The following is a description of a gene set: species: Mus musculus Genes down-regulated in NIH3T3 cells (fibroblasts) after treatment with Y27632, an inhibitor of ROCK proteins; the changes did not depend on expression of constitutively active (Q63L) form of RHOA. Human Gene Set: BERENJENO_ROCK_SIGNALING_NOT_VIA_RHOA_DN from publication Berenjeno IM, Núñez F, Bustelo XR (PMID 17213802) We have used microarray technology to identify the transcriptional targets of Rho subfamily guanosine 5'-triphosphate (GTP)ases in NIH3T3 cells. This analysis indicated that murine fibroblasts transformed by these proteins show similar transcriptomal profiles. Functional annotation of the regulated genes indicate that Rho subfamily GTPases target a wide spectrum of functions, although loci encoding proteins linked to proliferation and DNA synthesis/transcription are upregulated preferentially. Rho proteins promote four main networks of interacting proteins nucleated around E2F, c-Jun, c-Myc and p53. Of those, E2F, c-Jun and c-Myc are essential for the maintenance of cell transformation. Inhibition of Rock, one of the main Rho GTPase targets, leads to small changes in the transcriptome of Rho-transformed cells. Rock inhibition decreases c-myc gene expression without affecting the E2F and c-Jun pathways. Loss-of-function studies demonstrate that c-Myc is important for the blockage of cell-contact inhibition rather than for promoting the proliferation of Rho-transformed cells. However, c-Myc overexpression does not bypass the inhibition of cell transformation induced by Rock blockage, indicating that c-Myc is essential, but not sufficient, for Rock-dependent transformation. These results reveal the complexity of the genetic program orchestrated by the Rho subfamily and pinpoint protein networks that mediate different aspects of the malignant phenotype of Rho-transformed cells., and this is the list of marker genes: BOD1L1, COL4A2, KLF5 (NCBI Gene Id 688), ACTC1, TPM1, QKI, EGR1, PPP1CB, FASN, NRP1 (neuropilin 1), LUC7L3, COL4A1, SH3GLB1, SSB, ROCK1, F3 (NCBI Gene Id 99486), KLF6, EXT1 (NCBI Gene Id 3966), PAWR, VCL, CSF1, WWC2, PRSS23, SPARC, XBP1, HSPA5, MYH9, ACTA2, LPP, WSB1, SF3B1, JADE1, ATXN2, KAT2B, IER2, FERMT2, AMOTL2, MYL12A, NR2F2, UGCG, WSB2, PDLIM7 (NCBI Gene Id 9260), COL5A2, DOCK5 (dedicator of cytokinesis 5), ABRACL, SC5D, VCAM1 (vascular cell adhesion molecule 1), IGF1R